Given this list of marker genes Cd70, Ebag9, Tnfrsf14, Ighe, Cd81, Cd27, Cd160, here is a description of the gene set: species: Mus musculus Mouse Gene Set: GOBP_ADAPTIVE_IMMUNE_MEMORY_RESPONSE An immune response directed against a previously encountered antigen, being quicker and quantitatively better compared with the primary response.